The following is a description of a gene set: A ribonucleoprotein complex that contains an RNA of the box H/ACA type and the four core proteins dyskerin, NOP10, NHP2, and GAR1 (human protein nomenclature). RNA pseudouridylation (isomerization of uridine to pseudouridine) is the major, and most likely the ancestral, function of H/ACA RNPs. Pseudouridylation targets include both large and small ribosomal RNAs (rRNAs), and small nuclear RNA (U2 snRNA). In addition to these catalytic H/ACA RNPs, a less abundant but more diverse class of structural H/ACA RNPs exists, which does not have pseudouridylation activity. These include the vertebrate telomerase RNP complex. studied in species Homo sapiens Human Gene Set: GOCC_BOX_H_ACA_RNP_COMPLEX, and this is the list of marker genes: GAR1, NOP10, DKC1, SNORA73A, SNORA62, SNORA63, SNORA74A, NHP2, TERC